The following is a description of a gene set: Human Gene Set: GOBP_REGULATION_OF_NEUROBLAST_PROLIFERATION Any process that modulates the frequency, rate or extent of neuroblast proliferation. species: Homo sapiens, and this is the list of marker genes: DMRTA2, ZNF335 (NCBI Gene Id 63925), CX3CL1, LRRK2, GATA2, ID4, CDON, TP53, HIF1A, LHX5, FGF2, PROX1 (NCBI Gene Id 5629), SIX3, CTNNB1, VAX1 (NCBI Gene Id 196056), VSX2, SOX10, SHH, MIR137 (NCBI Gene Id 406928), BTG2, NOTCH1, KCTD11, NR2E1, VEGFA, NF1, FZD3, ITGB1, TGFB1, CTNNA1, VEGFC, GLI3, PAX6, WDR62 (NCBI Gene Id 4181), SMO, PTN, DRD2, KDM1A, CX3CR1, DCT, KIFAP3, OTP, FOXG1, TAFA1, SMARCD3, SKOR2, DISC1, ASPM